The following is a description of a gene set: studied in species Homo sapiens Human Gene Set: WP_DISORDERS_IN_KETONE_BODY_SYNTHESIS Disorders in ketone body synthesis, and this is the list of marker genes: OXCT1, ACAT1 (acetyl-CoA acetyltransferase 1), HMGCL, HMGCS2, BDH1